Given this list of marker genes GAL3ST3, ST8SIA1, AMY1C, FUT3, ST6GALNAC4, FUT10, HEXB, B3GALT5, MANBA, FUT9, MAN2B2, FUT7, GBA3, ST3GAL3, FUT5, GAL3ST4, GAA, B4GALNT2, B3GALT4 (NCBI Gene Id 87866), ST8SIA6, AMY1B, MAN2C1, FUT1, ST3GAL6, FUT4, NPC1, LALBA, NEU2, MGAM, LCT, AMY1A, B3GALT2, NEU4, CTBS, B3GALNT1, FUT2, FUT8, B4GALT1, ST8SIA3, IDUA, NAGA, GLA, ST8SIA2, ST6GALNAC3, SI, ST6GAL2, FUT6, MAN2B1, NEU3, ST8SIA5, ST6GALNAC1, ST3GAL2 (ST3 beta-galactoside alpha-2,3-sialyltransferase 2), ST3GAL4, MOGS, MAN1B1, MGAT2, ST6GALNAC6, ST8SIA4, MPDU1, GM2A, ST6GALNAC5, NEU1, B3GALT1, TREH, here is a description of the gene set: studied in species Homo sapiens The chemical reactions and pathways involving oligosaccharides, molecules with between two and (about) 20 monosaccharide residues connected by glycosidic linkages. Human Gene Set: GOBP_OLIGOSACCHARIDE_METABOLIC_PROCESS